The following is a description of a gene set: Human Gene Set: GOBP_RESPONSE_TO_TOXIC_SUBSTANCE Any process that results in a change in state or activity of a cell or an organism (in terms of movement, secretion, enzyme production, gene expression, etc.) as a result of a toxic stimulus. studied in species Homo sapiens, and this is the list of marker genes: AHR, MT1H, ATP7A, ABCB1, MT1E, CERS1, CDH1, GPX5, OSCP1, GSTM1, SLC22A8, MIR1-1, TRPA1, CCNB1, PENK, CCS, RDH12, RAD51, SESN1, HBB, ADH4 (alcohol dehydrogenase 4 (class II), pi polypeptide), SLC30A10, FMC1, FECH, DNMT3A, KCNC1, AIFM2, CD36 (NCBI Gene Id 948), SLC18A2, AKR1B10, PDZK1, BMP7, NEFL, LPO, CYP1A1, MPO, KDM6B, CCL4, SCFD1, GSTO1, HBE1, MGST3, CHUK, PRKCE, MUC2, SLC6A14, BAK1, EPHX1, ATP7B, PARK7, NHERF4, PIM1, PRKCA, ERCC6, GSTP1, PRDX6, CAT, CYP2F1, ALAS1, PRKCG, CPOX, AQP10, GPX8, FABP1, MT1G, CCL5, UBIAD1, PRKN, HBM, TTPA, SLC22A3, HBA1, TRPM6 (NCBI Gene Id 54817), MTARC2, MGST2, S100A9, SLC22A5, UBA52, CES1, KCNC2, HBG1, SELENOS, ABCG2, GPX6, GABRB1, HP, RAB40B, EPHX2, UGT1A10, MIR133A1, MIR873, MIR508, ESD, TXNDC17, HBZ, MIR133B, SESN2, GPX3, TXNRD3, MIR495, ASS1, CDH13, DHX15, BLMH (bleomycin hydrolase), COMT, BCL2, HTRA2, ALDH1A1, TXNRD1, SLC17A3, SCN9A, GSTK1, TXNDC2, DUOX2, GLYAT, SLC11A1, CYP1B1, DUOX1, AIFM1, NXN, GPX4 (NCBI Gene Id 2879), GSTA1, AMBP, PINK1, APOM, DHFR, MIR9-1, RDH11, TP53INP1, TXNRD2 (NCBI Gene Id 10587), APOE, GRIA1, MDM2, MT-CYB, GSTM3, HBA2, MT1B, ARHGAP33, PRDX1, EPX, SNN, GSTT1, MT3, MT4, SELENOT, PXDN, EDN1, MT1F, SOD1, PTGS1 (NCBI Gene Id 5742), XPA, UGT1A7, BAX, ALAD, GSTZ1, KDM1A (lysine demethylase 1A), PON3 (NCBI Gene Id 94886), MIR186, SRF, RALBP1, MIR34B, SRD5A1, GPX7, GCH1, SLC30A4, SLC22A1, IPCEF1, LTC4S, PON2, MIR451A, TXN, HBQ1, FIS1, CCL3, HBD, MT1DP, GSTO2, MT1A, SRXN1, SCN11A, SLC30A1, MIR185, INMT, DRD2, INHBB, CYGB, KDM3B, PTGS2, TNF, NQO1, SLC23A1, DHRS2, BPHL, COL6A1, ABCB6, MB, NFE2L2, SELENOF, PRDX4, PXDNL, SLC22A18, MBP, ALOX5AP, SLC7A11, SLC15A2, NUPR1, APOA4, ADH5, SLC29A4, SELENOW, PTPN13, GPX2, MTARC1, FOS, SLC47A2, MPST, MT1HL1, SLC22A2, NNT, CLDN1, PON1, PTGES, CDK1, SLC47A1, EDNRA, HBG2, MT2A, ALB (NCBI Gene Id 29004), CLIC2, GUCY2C, MT1M, CNP, MIR129-1, GJC2, MGST1, SOD2, PRDX3, ADAMTS13, SLC39A8, SLC6A4, GSR, GSTM2, LANCL1 (NCBI Gene Id 10314), AKR1A1, ABTB2, NOS3 (NCBI Gene Id 4846), PRDX5, LCN2, GPX1, MIR326, ABCG1, AQP8, RAB29, MT1X, KDM5B, SLC19A1, OPRD1, MAP1B, ATF4, FBLN5, DHFRP1, CP, PRDX2, AQP9, SOD3, PRXL2A, DDC, CPS1, EHMT1, AKR7A3, TPO, LYN (NCBI Gene Id 4067), SCN2B, ABCC5